The following is a description of a gene set: studied in species Homo sapiens Reactome Pathway: Signaling by TCF7L2 mutants part of: Signaling by WNT in cancer ~50% of colorectal cancers with microsatellite instability show frameshift mutations in TCF7L2 that result in the loss of the CTBP-binding region. These cancer cells show decreased colocalization of CTBP and TCF7L2 and have increased expression of a TCF-dependent reporter gene., and this is the list of marker genes: CTBP1, TCF7L2, CTBP2